The following is a description of a gene set: studied in species Homo sapiens Human Gene Set: GOBP_REGULATION_OF_AXON_EXTENSION_INVOLVED_IN_AXON_GUIDANCE Any process that modulates the frequency, rate or extent of axon extension involved in axon guidance., and this is the list of marker genes: WNT3, VEGFA, CXCL12, SLIT1, HDAC6, MEGF8, RYK, PLXNA3, NRP1, WNT3A, DSCAM, SEMA3A, WNT5A, SEMA3F, PLXNA4, BMPR2, SEMA5A